The following is a description of a gene set: species: Homo sapiens C-MYC pathway Human Gene Set: PID_MYC_PATHWAY from publication Schaefer CF, Anthony K, Krupa S, Buchoff J, Day M, Hannay T, Buetow KH (PMID 18832364), and this is the list of marker genes: SKP2, SUPT7L, ACTL6A, RUVBL1, PPP2CA, TAF12, PIN1, GSK3B, TAF10, SUPT3H, TAF9, ZBTB17, PML, PPP2R5A, FBXW7, RUVBL2, KAT5 (lysine acetyltransferase 5), TRRAP, HBP1, AXIN1, CDKN2A, KAT2A, PAK2, MAX, MYC